The following is a description of a gene set: Genes up-regulated in monocytes (6h): muramyl dipeptide versus muramyl dipeptide and M. tuberculosis 19 kDa lipopeptide. studied in species Homo sapiens Human Gene Set: GSE34156_NOD2_LIGAND_VS_NOD2_AND_TLR1_TLR2_LIGAND_6H_TREATED_MONOCYTE_UP human blood monocytes were isolated, activated and harvested at several timepoints In this study, we identified genes that were differentially expressed in human monocytes activated with eiter NOD2L and/or TLR2/1L. from publication Schenk M, Krutzik SR, Sieling PA, Lee DJ, Teles RM, Ochoa MT, Komisopoulou E, Sarno EN, Rea TH, Graeber TG, Kim S, Cheng G, Modlin RL (PMID 22447076), and this is the list of marker genes: NOB1 (NIN1 (RPN12) binding protein 1 homolog), TMEM11, CEP85L, MAP1B, POLR3G, GRAMD1C, LINC02604, POLR2J4, UBA52, JADE1, TMEM243, TUBE1, TTPAL, ZNHIT3, RPL39, PWAR5, REPS1 (NCBI Gene Id 85021), MAK16, RPF1, DKK3, RDH5, NOPCHAP1, LPIN1, PEX13, EEF1B2, ZNF805, PPDPF, SEPTIN7P2, CEP76, ATP5F1A, RIPK4 (NCBI Gene Id 54101), C10orf62, ZNHIT6, TMEM50B, SP3, NUP88, FBH1, RPAIN, MLLT3, COG2, SMIM27, STRBP, EAPP, MTRF1, SNRNP40, CDS2, CERS6, ALG6, MPHOSPH10, NSA2, LINC00960, C19orf53, ZNF655, TTC3, RIOK2, ACAD8, COQ9, RPL38, TAPT1, RPL7, CXorf58, SLC25A38, ARHGEF34P, ZRANB3, RPS13, PPT2, PSMD5, RPS18, DDI1, NAA16, LILRB5, TENT4A, SRSF1, COIL, CDIN1, LAS1L, CXorf65, KBTBD6, NOL7, NOL6, KBTBD4, CASD1, LINS1, MFHAS1, UTP23, CD8B, ETFRF1, WRNIP1, EIF2S1, SETD6, CTBP1-AS, CFAP44, PPWD1, PARP16, TNFAIP1, C8orf33, SYCE1L, ZNF770, TRIM52, USP37, METTL16, TRMT10C, PLXDC1, CIPC, YTHDC1, ZNRD2-DT, RPS3, QRICH1, RPL13, KLHL3, ZNF789 (NCBI Gene Id 285989), CCDC18-AS1, TNRC6C, FTSJ3, TRABD2A, PMPCB, UXT, CEACAM21, ZDHHC24, DQX1, RBM34, MBD5, PGBD4, C17orf75, NBEA, ZNF451, ARMC1, RPSA, PDRG1, RPL19, SERINC3, RPL27, WDR44, UTP15, ZC3H13, NDFIP1, MAGEH1, HSP90AB1, RPL11, KDM2A, FOXO1, SRD5A2, DNHD1, ELF2 (NCBI Gene Id 1998), C14orf93, RPS29, RPUSD4, TRAPPC4, RASA2, TAS2R4, LINC00339, USP16, LPCAT3, POLR2C (RNA polymerase II subunit C), IFT70B, RIMS4, PAXBP1, SEC31B, UBP1, SERBP1, TCF20, ANAPC4, MAL (NCBI Gene Id 4118), CFAP68, LRRN1, PRMT5, WDR33, PUS3 (pseudouridine synthase 3), MYH3, CCNB1IP1, MRPS25, ADAM2, OSGEP, SLC41A1, PNN (pinin, desmosome associated protein), MTREX, PSMD6, SARNP, PVT1, MED6, FBL, LCDR, SNHG29, WRAP73, GFOD3P, NDUFAF6, AP4B1, TRIM63, TMEM116, AMT, FAM86C1P, FGFR1OP2, KLHDC2, CDKN2AIP, JTB, TRIAP1